Given this list of marker genes Yars1, Rpp25, Trmt9b, Pstk, Hars2, Rpp21, Thumpd3, Trub2, Pus3, Rpp14, Gatb, Prorsd1, Pars2, Trmt1, Wars2, Pop4, Vars1, Trmu, Ptrh2 (NCBI Gene Id 217057), Aarsd1, Ptrh1, Rpp38, Trit1, Ang, Dus4l (NCBI Gene Id 78387), Dtwd2, Mtfmt, Trpt1, Rars1, Trmt11, Trmt10b, Dars2, Dus2, Fto, Pop5, Mrpl58, Gatc, Mettl8, Alkbh1, Nars2, Tars2, Cars2, Tsen2, Lars1, Trmt44, Trmt13, Trub1, Nars1, Ptrhd1, Pus10, Trnt1, Dtwd1, Thg1l, Kars1, Mars1 (methionine-tRNA synthetase 1), Farsa, Qars1, Dars1, Pop1, Gars1, Aars2, Qtrt1, Ears2, Sars2, Dus1l, Dtd2, Tars1, Pus1, Tyw3, Rpp40, Nsun2, Tarbp1, Cars1, Mettl6, Prorp, B3gntl1, Ankzf1, Nsun6, Nsun3, Lcmt2, Yars2, Rpp30, Trmo, Trmt12, Trmt2b, Farsb, Rpusd4, Ggt5, Tyw5, Lars2, Fars2, Pop7, Aars1, Etf1, Mettl1, Trmt1l, Alkbh8, Dtd1, Tyw1, Vars2, Pus7, Trmt10c, Hars1, Wars1, Rars2, Iars2 (isoleucine-tRNA synthetase 2, mitochondrial), Sars1, Elac1, Trmt61a, Tsen34, Pusl1, Mettl2, Tars3, Ggt1, Lrrc47, Nsun4, Dalrd3 (DALR anticodon binding domain containing 3), Eprs1, Dus3l (dihydrouridine synthase 3 like), Mars2, Qtrt2, Trdmt1, Trmt10a, Bcdin3d, Ftsj1, Cdk5rap1 (CDK5 regulatory subunit associated protein 1), Trmt2a, Elac2, Trmt5, Iars1, Qrsl1, Cdkal1, Sepsecs, Gtdc1, Thumpd2, here is a description of the gene set: Catalytic activity that acts to modify a tRNA. species: Mus musculus Mouse Gene Set: GOMF_CATALYTIC_ACTIVITY_ACTING_ON_A_TRNA